The following is a description of a gene set: An immune response dependent upon secreted immunoglobulin. An example of this process is found in Mus musculus. species: Mus musculus Mouse Gene Set: GOBP_HUMORAL_IMMUNE_RESPONSE_MEDIATED_BY_CIRCULATING_IMMUNOGLOBULIN, and this is the list of marker genes: Ptpn6, Gimap3, Igha, Ighm, Nod2, Cr2, C4b, Susd4, Cd55, C1rl (complement component 1, r subcomponent-like), Gimap5, Ighg3, Trem2, Crp, Ptprc (NCBI Gene Id 19264), Foxj1, C1qbp, Hpx, Hc, Serping1, Lta, Ighg1, Mbl1, C1qa (NCBI Gene Id 12259), Exo1, C1rb, Cfi, C2, C8a, Cd55b, Ighg2b, Fcer2a, Cd81, C1qc, Zp3, C8b, Mbl2, Tnf, Ighe, Bcl3, Ighg2c, C1s2, Masp2, C4bp, C1qb, C1s1 (complement component 1, s subcomponent 1), C9 (complement component 9), C8g (NCBI Gene Id 69379), Fcmr, Cd46, Fcgr2b, C3, Zp3r, C1ra, Cr1l